Given this list of marker genes FABP3, SLN, MYL11, CLU, NQO1, LSP1, PPFIA4, OCEL1, MYOM1, SCD, FST, EPHB3, MYF6 (NCBI Gene Id 4618), APLNR, SLC6A8, PDE4DIP (NCBI Gene Id 9659), SOD3, MYOZ1, MEF2C, GJA5, ANKRD2, IGFBP7, FDPS, IGFBP3, CASQ1, CKB, CACNA1H, TNNT3, PRNP, SPDEF, PFKM, SSPN, ACTA1, AGL, DAPK2, CFD, KLF5, FGF2, ERBB3, CD36, TNNI1, TPM3, IGF1, GADD45B, SPHK1, PGAM2, RB1, BDKRB2, ACHE, TNNT2, LDB3, MYL6B, ACTN2, COX7A1, TPD52L1 (TPD52 like 1), ACTC1, MYOG, MYH9, GAA, TSC2, TGFB1, SH2B1, TPM2, SORBS1, GPX3, DMPK, MYL7, COX6A2, PTP4A3, EIF4A2, COL3A1, RIT1, CKM (creatine kinase, M-type), HRC, SIRT2, AK1, APP, CDKN1A, MYH11, MYBPH, AEBP1, HSPB8, NAV2, PDLIM7, CSRP3, CKMT2, LAMA2, MYO1C, MYH1, MAPRE3, EFS, MB, ITGA7, BHLHE40, NCAM1, HSPB2, MYOM2, MYL4, ITGB1, COL1A1, FOXO4, WWTR1, MYBPC3, CRAT, ATP2A1, CAV3, VIPR1, ADAM12, SPARC, MYH8, MYL2, COL15A1, MEF2D, SCHIP1, TNNI2, MYH2, FLII, ACTN3, SH3BGR, AGRN, NOS1, CDH13, DTNA, CTF1, SPEG, LARGE1, COL4A2, TEAD4, COL6A3, HBEGF, ATP6AP1, TAGLN, SGCG, FKBP1B, MYLK, FXYD1, GNAO1, IFRD1, MRAS, CASQ2, BAG1, CACNG1, DMD, PTGIS, CHRNB1, ADCY9, MYH4, GABARAPL2, SGCA, SORBS3, TCAP, APOD, SMTN, MYL3, DENND2B, SGCD, AKT2 (NCBI Gene Id 208), DES, PICK1, ITGB4, PPP1R3C, CRYAB, SPTAN1, LPIN1, PYGM, TNNC1, SYNGR2, PC, GSN, RYR1, ENO3, REEP1, PKIA, CHRNA1, TNNC2, CNN3, STC2, KIFC3, MYH7, KCNH1, MAPK12, CHRNG, PVALB, CAMK2B, MYL1, ITGB5, SVIL, COL6A2, ACSL1, PSEN2, KCNH2, MEF2A, TNNT1, MYH3, FHL1, BIN1, NOTCH1, HDAC5, ABLIM1, PLXNB2, here is a description of the gene set: Human Gene Set: HALLMARK_MYOGENESIS Genes involved in development of skeletal muscle (myogenesis). from publication Liberzon A, Birger C, Thorvaldsdóttir H, Ghandi M, Mesirov JP, Tamayo P (PMID 26771021) studied in species Homo sapiens